The following is a description of a gene set: Genes predicted to be targets of miRBase v22 microRNA hsa-miR-8064 in miRDB v6.0 with MirTarget v4 prediction scores > 80 (high confidence targets). from publication Chen Y, Wang X (PMID 31504780) Human Gene Set: MIR8064 species: Homo sapiens, and this is the list of marker genes: STMP1, PAFAH1B1, AFG1L, UHRF2, SLC6A19, SPAST, ELOVL5, ANOS1 (NCBI Gene Id 3730), VSTM4, CHODL, BNC2, KCNC2, FILIP1L, MAP3K20, FBXO30, WSB2, SMG7, ADCYAP1, TMEM179, DYNC1I1 (dynein cytoplasmic 1 intermediate chain 1), GPR161, GADL1, A1CF (APOBEC1 complementation factor), NNAT, ADAM17, MAP3K5, YOD1, ITGAM, ZBTB33, PMAIP1, SPTBN1, TDP2, ATP6AP2 (ATPase H+ transporting accessory protein 2), ASTN1, C2orf49, CNEP1R1, DUSP10, TNRC18, DOK3, UBE2N, SLC6A17, PCGF5, MAP1B, CRY2, DCUN1D4, PNPLA3, AGO3, UBE2W, VDAC2, KCNMA1, CHIC2, SF3B1, AAK1, SPRY3, CDK5R1, WDFY3 (WD repeat and FYVE domain containing 3), PCDH10, AKAP12, AGBL3, PGGT1B, GEN1, ZNF248, RLF, FRMD4B, MS4A2, LPGAT1, BCL11A, MYT1L, SMG1, C1orf216, PPP3CA, UBR4, PPP1CB, AQP2, DIPK1C, USH1G, JMY, RFX3 (NCBI Gene Id 5991), CLIC5, ZBTB20, DMD, ARHGAP32